The following is a description of a gene set: Mouse Gene Set: MIR_6964_5P Genes predicted to be targets of miRBase v22 microRNA mmu_miR_6964_5p in miRDB v6.0 with MirTarget v4 prediction scores > 80 (high confidence targets). studied in species Mus musculus from publication Chen Y, Wang X (PMID 31504780), and this is the list of marker genes: Cmtr1, Txnip, Nfix, Gdpd4, Zfp592, Stum, Islr, Slc18b1, Rnf44 (ring finger protein 44), Itpkc, Dpm1, Slc13a5, Tspan18, Tm2d2, Arl6ip6, Slc36a4, Atp10b, Dcn, Tbc1d16, Col11a2, Rgp1, Eif4a2, Fibcd1, Rfng, Bsn, Acnat2, Dnajb5, Trim28, Ptprcap, Zfhx2, Vwa3a, St3gal2, Zdhhc20, Rho, Nrxn2, Frmd6, Atp6v0a1, Tsr2, Smg6, Slc25a23, Clip3, Cyp2c23, Lrrc4b (NCBI Gene Id 272381), Upk1a, Arhgef17, Grpel2, Acsm2, Zfp579, Plxna4, Dagla, Eeig1, Pip4k2b, Fzd8, Ptpn7 (protein tyrosine phosphatase, non-receptor type 7), Vdr (NCBI Gene Id 22337), Mboat1, Zdhhc8, Fgd2, Foxp3, Efna4